The following is a description of a gene set: Any process that modulates the frequency, rate or extent of epithelial cell differentiation. species: Mus musculus Mouse Gene Set: GOBP_REGULATION_OF_EPITHELIAL_CELL_DIFFERENTIATION, and this is the list of marker genes: Cdh5, Pax6, Ctnnb1, Fgfr3, Fat4, Foxj2 (forkhead box J2), Ceacam1, Sall1, Prkx, Smo, Eppk1, Fgf2, Pax8, Bmp7, Spred2, Serpine1, Stat5b, Vcl, Cul7, Hes1, Sfrp4, Gdf2, Vdr, Bmpr1a, Sfn, Tlr9, Dspp, Cyp27b1, Zeb2, Plcb1, S1pr2, Tnfrsf1a, Zdhhc21, Dll1, Prom1, Sox2, Med1, Ajap1, Ahi1, Nodal, Gata3, Dsg2, Atoh1, Gdnf, Rock1, Macroh2a1, Cldn5, Foxn1, Add1, Kras, Krt84, Msx1, Foxp1 (forkhead box P1), Atoh8, Trp63, Bmp2, Bmp6, Notch4, Tgfb2, Apc, Spry2, Cited1, Lif, Hey2, Hey1, Reg3g, Hes5, Foxp4, Etv4, Tbx3, Spry1, Apold1, Ptch1, Zfp36, Cd109, Foxa3, Zfp36l1, Ascl1, Osr1, Btg1, Msx2, Sgpp1, Zeb1, Spred1, Id1, Gdf3, Krt36, Sult2b1, Six2, Bad, Pax2 (NCBI Gene Id 207129), Cav1, Wnt9a, Keap1, Pkp1, Kdf1, S1pr3, Ptch2, Foxe3, Prkch, Nkx2-2, Reg3a, Foxc1, Mycn, Cebpb, Ncoa3, Dicer1, Commd5, Ovol2, Skint1, Etv2, Vezf1, Stat1 (signal transducer and activator of transcription 1), Wnt9b, Pinc, Prlr, Rptor, Tmem100, Klf7, Il1a, Foxj1, Hoxa7, Cdkn1b, Lef1, Grhl1, Esrp1, Mir7-1, Notch1, Proc, Maff, Il1b, Ccnd1, Mafg, Akap11, Fgf10, Pax4, Cdkn2b, Lhx1, Ipo7, Spred3, Alox8, Vhl, Ikbkb, Vegfa, Extl3, F11r, Cd24a (NCBI Gene Id 12484), Mesp1, Abca12, Fst, Ifng, Mycl, Wwtr1, Rfx3, Rock2, Macroh2a2, Jag1, Cdkn1c (cyclin dependent kinase inhibitor 1C), Nfe2l1, Nme2, Srsf6, Frzb, Wnt10b, Tgfbr1, Tnf, Nkx6-3, Numa1, Bmp4, Xdh, Trp73, Mmp9, Ezh2, Acvrl1, Dmbt1, Stat5a, Csf1r, Sox9, Errfi1, Yap1